The following is a description of a gene set: Selective estrogen receptor modulators (SERMs) such as tamoxifen are effective in the treatment of many estrogen receptor-positive breast cancers and have also proven to be effective in the prevention of breast cancer in women at high risk for the disease. The comparative abilities of tamoxifen versus raloxifene in breast cancer prevention are currently being compared in the Study of Tamoxifen and Raloxifene trial. To better understand the actions of these compounds in breast cancer, we have examined their effects on the expression of approximately genes, using Affymetrix GeneChip microarrays, with quantitative PCR verification in many cases, categorizing their actions as agonist, antagonist, or partial agonist/antagonist. Analysis of gene stimulation and inhibition by the SERMs trans-hydroxytamoxifen (TOT) and raloxifene (Ral) or ICI 182,780 (ICI) and by estradiol (E2) in estrogen receptor-containing MCF-7 human breast cancer cells revealed that (a) TOT was the most E2-like of the three compounds, (b) all three compounds either partially or fully antagonized the action of E2 on most genes, with the order of antagonist activity being ICI > Ral > TOT, (c) TOT and Ral, but not ICI, displayed partial agonist/partial antagonist activity on a number of E2-regulated genes, (d) several stimulatory cell cycle-related genes were down-regulated exclusively by ICI, (e) the estrogen-like activity of Ral nearly always overlapped with that of TOT, indicating that Ral has little unique agonist activity different from that of TOT, and (f) some genes were specifically up-regulated by TOT but not Ral, ICI, or E2. Hence, gene expression profiling can discern fundamental differences among SERMs and provides insight into the distinct biologies of TOT, Ral, and ICI in breast cancer. from publication Frasor J, Stossi F, Danes JM, Komm B, Lyttle CR, Katzenellenbogen BS (PMID 14973112) Human Gene Set: FRASOR_RESPONSE_TO_SERM_OR_FULVESTRANT_DN Genes down-regulated in MCF-7 cells (breast cancer) by selective estrogen receptor modulators (SERM) 4-hydroxytamoxifen, raloxifene, or ICI 182780 but not by estradiol. species: Homo sapiens, and this is the list of marker genes: CDC20, MCM7 (NCBI Gene Id 4176), AURKA, KIF11, WEE1, MYB, CKS1B, CDK1, MCM3, STMN1, RRM1, BRPF1, CDKN2C, POLA2 (NCBI Gene Id 23649), MTHFD1, RFC2 (replication factor C subunit 2), MYC, CENPF, TK1, BARD1, NUDT1, MAZ, NFRKB, POLRMT, RNASEH2A, POLE, MYRF, MCM5 (NCBI Gene Id 4174), RFC5, E2F1, PRIM1, UBE2C, GAL, CAP2, H2AX, CDK8, MCM2, KIF2C, CCNA2, TIMELESS, FOXM1, CDC25B, FKBP1A, BLM, TTLL4, RNF126, CHAF1A, MCM6, HOXA11